Given this list of marker genes CARTPT, ITGA2, CHRNB4, HCRT, MTNR1B, GBA1, TNR, here is a description of the gene set: Human Gene Set: GOBP_POSITIVE_REGULATION_OF_TRANSMISSION_OF_NERVE_IMPULSE studied in species Homo sapiens Any process that activates, maintains or increases the frequency, rate or extent of transmission of a nerve impulse, the sequential electrochemical polarization and depolarization that travels across the membrane of a neuron in response to stimulation.